The following is a description of a gene set: Reactome Pathway: Noncanonical activation of NOTCH3 part of: NOTCH3 Activation and Transmission of Signal to the Nucleus species: Homo sapiens Besides DLL/JAG ligands, NOTCH3 signaling can also be activated by binding of NOTCH3 to YBX1 (YB 1). YBX1, a protein involved in mRNA processing, is secreted by mesangial cells and monocytes during inflammation and acts as an extracellular mitogen. YBX1 triggers the gamma secretase complex mediated cleavage of NOTCH3, resulting in release of NOTCH3 intracellular domain (NICD3) and activation of NOTCH3 target genes., and this is the list of marker genes: PSENEN, PSEN1, NCSTN, APH1B, YBX1, NOTCH3, APH1A, PSEN2